The following is a description of a gene set: Mouse Gene Set: chr3F2 species: Mus musculus, and this is the list of marker genes: Tuft1, Gm12490, Reg4, Vps45, Acp6, Pde4dip (NCBI Gene Id 97109), Adora3, Rfx5 (regulatory factor X, 5 (influences HLA class II expression)), Gm9131, A930002I21Rik, BC028528, Gm19211, Igsf3, Sort1, Gm19210, 9530097N15Rik, Gm15264, C920021L13Rik, Rnu1b2, H2ac19, Ctsk, Mir7013, Arnt, Wdr77, H2ac21, Slc22a15, Lrig2, Gm38411, Pafah1b1-ps1, Nhlh2, Gpr61, Pogz, Tpt1-ps1, Gm9173, H3c13, Rbm15, Rap1a, Cyb561d1, Fmo5, Phgdh, Gm17815, BC107364, Tchhl1, Gm5279, C030032O16Rik, Cd101, Gm15472, Gnat2, Tars2, S100a10, Gm24435, H3c15, Gm4248, Gm12500, Gdap2, 4930554G22Rik, Txnip, Kcnc4, Gstm5, A730011C13Rik, Hsd3b5, Scnm1, Ankrd34a, Hsd3b9, Tmigd3, Gm25592, Sv2a, Amigo1, Mir8099-1, Gm37500, Vps72, Adamtsl4, Mir7225, Polr3c, Spag17, Magi3, Cd53, Gm4525, Trim45, Gm27008, Gm6522, Ptgfrn, Gm5541, Prpf3, Sema6c, Psmd4, 1700010K24Rik, Tspan2os, Gm9169, Tdpoz6, Bola1, Ahcyl1, Gm12428, Gm29950, Or11i1, Mcl1 (NCBI Gene Id 99928), Mab21l3, Hsd3b8, Gm9771, 2010016I18Rik, Rpl21-ps11, Gm5075, Itga10, Cd2, Gm9141, Wars2, C2cd4d, Hrnr, Them5, Lamtor5, Tnfaip8l2, Gm5852, Hsd3b1, Gm40123, Nras, Gm25199, Aph1a, Gm26361, Lysmd1, Olfml3, A630076J17Rik, Ngf, 6330562C20Rik, Hipk1, Flg2, Gm33952, Csf1, 4930477E14Rik, Bcl9, Gm20627, H2bc18, Ctxnd2, Prok1, Gm16253, Rbm8a, Gm15886, Hsd3b4, Cept1, Gm23077, Rhoc (ras homolog family member C), Gm19202, Sike1, Gabpb2, Gm38412, Gm15441, Gm17956, Gm5542, Setdb1, BC021767, Gm15234, Mir7014, Adam30, Ptpn22 (NCBI Gene Id 19260), Platr30, Rorc, Mov10, Gm10961, Cers2, I830077J02Rik, Nudt17, Gm12497, Pdzk1, H3c14, Gm9207, Cdc42se1, Wdr3, Tdpoz3 (NCBI Gene Id 399674), Casq2, Gstm1, Gm22505, 4933431E20Rik, Gm30023, 4930564D02Rik, Capza1, Rplp0-ps1, Slc16a1, Dennd2d, Them4, Alx3, Tdpoz9, Ampd2, Sec22b (NCBI Gene Id 99656), AI504432, Gm12400, Gm5278, Chil3, Ubl4b, Kcna10, Tdpoz5, 9230114J08Rik, Gm33866, Chil5, Gm31305 (NCBI Gene Id 102633492), Gm35507, Gm12494, Gm42722, Gm12399, Celf3, Psma5, Gm26553, Riiad1, Gm15471, Gm12441, Hsd3b6, Tdpoz1, Spopfm2, Gm9121, Gm18982, Gm12502, Nr1h5, Pip5k1a, Polr3gl, 6330549D23Rik, Gstm7, Slc16a4, Prune1, Sycp1, H2ac18, Kcnd3os, Gm9116, Gm22301, Anxa9, Gm12498, Gm15602, Gm18432, M6pr-ps (NCBI Gene Id 17114), Ampd1, Gm18296, Gm128, Rpl31-ps11, Trim33, Gm5547, Ctss, Eps8l3, Ciart, Gm9678, Rps10-ps1, Cd160, Gm5773, Lrif1, H4c14, Gm15263, Gm25009, Gm5543, Gstm3, Dennd2c, Hao2, Mrpl9, Gm12464, Ppm1j, Tdpoz2, Plekho1, 4930406D18Rik, Pi4kb, Strip1, Wnt2b, Gja5, Gm18433, Rptn, Gm12501, Dram2, Rpl36-ps7, Cym, Mindy1, Tdpoz7, Gstm6, Atg4a-ps, S100a11, Vangl1, Gm22826, Ensa, Gm25802, 4930442L01Rik, Hmgcs2, Dclre1b, Gm36953, Gm25890, Bcas2, Fcgr1, Gm5546, Gm16160, Prkab2, Spag17os, Sf3b4 (NCBI Gene Id 223612), Gm22341, Phtf1, Terc, Psmb4, Spopfm1, Kcna3, Gm12474, Mir6481, Oaz3, Chd1l, Chil4, Chil6, Gm22027, A530041M06Rik, Ovgp1, Spopfm3, Atxn7l2, Hmgb1-ps5, A230001M10Rik, Selenbp2, Gm4540, Gm5853, 4632404M16Rik, Vtcn1, Gm5070, 1700040D17Rik, Lix1l, Cimap3, Bcl2l15, Gm9515 (predicted gene 9515), Atp5pb, Gm4349, Gm6485, Selenbp1, Tdpoz9-ps1, Golph3l, Gstm4, Gm20940, Hsd3b2, Ap4b1, Cgn, Gm26654, Ecm1, 5730437C11Rik, Lingo4, Gm18894, Gja8, Tdpoz4, Gm4982, Gm24216, Gm12449, Car14, Gm9113, Gstm2, Gm36070, Hsd3b3, Tmod4, Tshb, Or13l2 (NCBI Gene Id 258272), Rnf115, Hjv, Bnipl, Phtf1os, Zfp687, Hormad1, Gm9504, Pex11b, Mrps21, Gm12440, Gm12486, Ttf2, B230398E01Rik, Gm9273, Flg, Gm17690, Zfp697, Ankrd35, Gnai3, Gpr89, Syt6 (NCBI Gene Id 99876), Atp1a1, Tbx15, Tdrkh, St7l, Otud7b, Inka2, Kcna2, Cttnbp2nl, Tchh, 4930509H03Rik, Chia1, Mtmr11, Man1a2, Gm24223, Mllt11, Rprd2, Tent5c, Gm36211 (NCBI Gene Id 118568636), Gm22581, Anp32e, Gm9124, Gm24920, Slc6a17, Tafa3, E330034L11Rik, Tspan2, Pias3, Gm26279, Ddx20, Gm10685, Gm16740, Sypl2, H2ac20, 4930481B07Rik, 4930573H18Rik, Gm40117, Gm43464, Gm15235, Rsbn1, Gm10355, Notch2, Kcnd3, Snx27, H2bc21, Csde1, Gm5544